Given this list of marker genes MRAS, SHOC2, YWHAB, PPP1CB, BRAF, ARAF, RAF1, PPP1CC, here is a description of the gene set: part of: Signaling by MRAS-complex mutants Reactome Pathway: Gain-of-function MRAS complexes activate RAF signaling species: Homo sapiens This pathway describes the effect of activating mutations of MRAS-complex components on RAF activation (reivewed in Simanshu et al, 2017).